The following is a description of a gene set: Human Gene Set: GOBP_NEGATIVE_REGULATION_OF_NON_CANONICAL_NF_KAPPAB_SIGNAL_TRANSDUCTION species: Homo sapiens Any process that stops, prevents or reduces the frequency, rate or extent of non-canonical NF-kappaB signaling cascade., and this is the list of marker genes: TRIM60, MIR15B, MIR29B1, NDUFC2, MIR132, RASSF2, LITAF, NLRP12, CPNE1, PYDC2, DDX3X, MKRN2, NLRC3, HDAC7, MIR27B, CYLD, C1QTNF3, MIR149, NMI, BMP7, UACA, MIR21, TRIM15, NLRP3, SPI1, FOXJ1, RELA, MIR9-1, ZC3H12A, MIR766, MIR508, IFI35, PPM1B, CCN3, MIR204 (microRNA 204), ADGRG3, TRIM40, ADIPOR1, DAB2IP, NLRP2, PPM1A, MIR223